Given this list of marker genes GGCX, F9, here is a description of the gene set: Naturally occurring hemophilia B (HB)-associated point mutations in the FIX propeptide sequence reduce affinity to gamma-glutamyl carboxylase (GGCX) resulting in reduced γ-carboxylation and aberrant propeptide processing (Bentley AK et al. 1986; Rabiet MJ et al. 1987; Diuguid DL et al. 1986; Ware J et al. 1989; de la Salle C et al. 1993). Unprocessed FIX variants such as F9 N43Q/L or F9 N46S, circulate with the attached propeptide and show delayed FIX activation (Bentley AK et al. 1986; Diuguid DL et al. 1986; Ware J et al. 1989; de la Salle C et al. 1993). Reactome Pathway: Defective gamma-carboxylation of F9 studied in species Homo sapiens part of: Defective factor IX causes hemophilia B